The following is a description of a gene set: Regucalcin in proximal tubule epithelial kidney cells Human Gene Set: WP_REGUCALCIN_IN_PROXIMAL_TUBULE_EPITHELIAL_KIDNEY_CELLS species: Homo sapiens, and this is the list of marker genes: APAF1, BAK1, FFAR3, MAPK1 (NCBI Gene Id 5594), AKT1, CRYZL2P-SEC16B (CRYZL2P-SEC16B readthrough), PDE1B, MCU, ACTA2, CASP9, SMAD4, CASP8, PIK3CA, G3BP1, PPP3R1, TGFBR1, SMAD2, TNFRSF1A, RGN, CALCA, CASP3, TGFB1, PTH, MAP3K5, NOS1, RAF1, TNFSF11, BRAF, MTOR, TRPV5, BAX (NCBI Gene Id 581), SEC16B